Given this list of marker genes ID2, PLEK, ICAM3, RAC2, PRF1, XCL1, HLA-F, SRGN, LITAF, ACAP1, CST7, CD44, LY6E, CMC1, SPON2 (spondin 2), TARP, FKBP11, ABI3, CLEC2B, DENND2D, HLA-A, ARPC5L, PSMB9, ADAM8, KLRF1, DOK2, CD247, LIMD2 (NCBI Gene Id 80774), GMFG, SEPTIN6 (septin 6), AKNA, CD244, GIMAP4, LCK, KLRB1, PTPRC, CLIC1, NHERF1, PLAAT4, HSH2D, RAP1B, ZAP70, BTN3A2, HLA-H, SH2D1A, TSTD1, CD48, S100A4, EOMES, CD7, PVRIG, PTPN4, STK17B, GZMA, HCST, MYL12A, CLIC3 (chloride intracellular channel 3), EMP3, GZMB, CD96, SAMD3, SEPTIN1, IQGAP2 (IQ motif containing GTPase activating protein 2), LSP1, IL2RG, IL18RAP, PTPRCAP, TXNIP, CD69, ITGAL, HLA-B, TXK, GPR65, PIP4K2A, IQGAP1, PRKCH, CHST12, SH2D1B, NKG7, HOPX, LCP1, CYTIP, CD160, CCND3, IFITM2, MSN (NCBI Gene Id 4478), KLRC1, CRIP1, FGR, PYHIN1, SYNE1, STK10, DUSP2, IRF1, RUNX3, FGFBP2, GIMAP7, ARHGEF3, TMEM71, APOBEC3G, XCL2, PRKACB, CDC42SE2, IL2RB, DGUOK, CTSW, SKAP1, S1PR5, CCL4, FYN, TBC1D10C, RIPOR2 (RHO family interacting cell polarization regulator 2), GZMH, HLA-C, STAT4, SYTL1, LINC00861, ARID5A, CORO1A, SH2D2A, IFITM1, KLRC3, RASSF5, KLRD1, CARD16, SLAMF7, TSEN54, BTG1, CD3E, ADGRE5, LAIR2, PLAC8, here is a description of the gene set: species: Homo sapiens Human Gene Set: FAN_EMBRYONIC_CTX_BRAIN_EFFECTOR_T_CELL from publication Fan X, Dong J, Zhong S, Wei Y, Wu Q, Yan L, Yong J, Sun L, Wang X, Zhao Y, Wang W, Yan J, Wang X, Qiao J, Tang F (PMID 29867213)